The following is a description of a gene set: The chemical reactions and pathways involving tyrosine, an aromatic amino acid, 2-amino-3-(4-hydroxyphenyl)propanoic acid. species: Mus musculus Mouse Gene Set: GOBP_TYROSINE_METABOLIC_PROCESS, and this is the list of marker genes: Fah, Pcbd1, Slc45a2, Il4i1, Thap4, Iyd (iodotyrosine deiodinase), Th, Gstz1, Hpd, Tat, Pah, Dct, Oca2, Ttc36, Atp7a, Pcbd2, Tyrp1, Hgd